Given this list of marker genes SFTPC, SFTPA1, CSF2RA, SFTPB, CSF2RB, SFTA3, SFTPA2, SFTPD, here is a description of the gene set: studied in species Homo sapiens Reactome Pathway: Defective CSF2RB causes SMDP5 Surfactant catabolism by alveolar macrophages plays a small but critical part in surfactant recycling and metabolism. Upon ligand binding, granulocyte-macrophage colony-stimulating factor receptor (GM-CSFR), a heterodimer of alpha (CSF2RA) and beta (CSF2RB) subunits, initiates a signalling process that not only induces proliferation, differentiation and functional activation of hematopoietic cells but can also determine surfactant uptake into alveolar macrophages and its degradation via clathrin-coated vesicles. Defects in human CSF2RB can cause pulmonary surfactant metabolism dysfunction 5 (SMDP5; MIM:614370, aka pulmonary alveolar proteinosis 5, PAP5), a rare lung disorder due to impaired surfactant homeostasis characterised by alveoli filling with floccular material causing respiratory failure (Greenhill & Kotton 2009, Whitsett et al. 2015). part of: Diseases associated with surfactant metabolism